The following is a description of a gene set: The loss of gum tissue. The result is that gum tissue is recessed and its position on the tooth is lowered, exposing the roots of the teeth. species: Homo sapiens Gingival recession Human Gene Set: HP_GINGIVAL_RECESSION, and this is the list of marker genes: C1R, CTSC, VAC14, COL3A1, C1S, FIG4, DSP